Given this list of marker genes Fbxo45, Bhlhe22, Spg11, Prdm8, Scn1b, Zeb2, Nin, Epha4, Cdh11, Slit2, here is a description of the gene set: Mouse Gene Set: GOBP_CORTICOSPINAL_TRACT_MORPHOGENESIS species: Mus musculus Generation of a long process of a pyramidal cell, that carries efferent (outgoing) action potentials from the cell body in cerebral cortex layer V towards target cells in the gray matter of the spinal cord. This axonal process is a member of those that make up the corticospinal tract.